Given this list of marker genes MESP1, DVL1, VANGL2, FRZB, WNT5A, DVL2 (dishevelled segment polarity protein 2), here is a description of the gene set: Human Gene Set: GOBP_CONVERGENT_EXTENSION_INVOLVED_IN_ORGANOGENESIS species: Homo sapiens The morphogenetic process in which an epithelium narrows along one axis and lengthens in a perpendicular axis contribution to the shaping of an organ.